The following is a description of a gene set: Thirty-eight PBMC samples from 25 patients with IPF and 13 matched controls yielded 149,564 cells that segregated into 23 subpopulations. Classical monocytes were increased in progressive and stable IPF compared to controls (32.1%, 25.2%, 17.9%, respectively, p<0.05). Total lymphocytes were decreased in IPF vs controls, and in progressive vs stable IPF (52.6% vs 62.6%, p=0.035). Tregs were increased in progressive vs stable IPF (1.8% vs 1.1% of all PBMC, p=0.007), although not different than controls, and may be associated with decreased survival (P=0.009 in Kaplan-Meier analysis; P=0.069 after adjusting for age, sex, and baseline FVC). Flow cytometry analysis confirmed this finding in an independent cohort of IPF patients. Fraction of Tregs out of all T cells was also increased in two cohorts of lung scRNA-seq. CCL22 and CCL18, ligands for CCR4 and CCR8 Treg chemotaxis receptors, were increased in IPF. The single-cell atlas of the peripheral immune system in IPF, reveals an outcome-predictive increase in classical monocytes and Tregs, as well as evidence for a lung-blood immune recruitment axis involving CCL7 (for classical monocytes) and CCL18/CCL22 (for Tregs). (From Abstract) from publication Unterman A, Zhao AY, Neumark N, Schupp JC, Ahangari F, Cosme C Jr, Sharma P, Flint J, Stein Y, Ryu C, Ishikawa G, Sumida TS, Gomez JL, Herazo-Maya JD, Dela Cruz CS, Herzog EL, Kaminski N (PMID 38717443) Human Gene Set: UNTERMAN_IPF_VS_CTRL_TREG_CELL_DN studied in species Homo sapiens Genes downregulated in Treg cells from Progressive Idiopathic Pulmonary Fibrosis Patients vs. Stable Non-Progressors, and this is the list of marker genes: TENT5C, CD69, HLA-DQB1, H3-3B, CXCR4, DUSP4, KANSL1-AS1, ZFP36, PMAIP1, UBC, PTGER4, SBDS, SRSF7 (serine and arginine rich splicing factor 7), DNAJB1, BTG2, MALAT1, JUNB, NR4A2, CSRNP1, DUSP2, TNFAIP3